The following is a description of a gene set: Mouse Gene Set: GOBP_SINGLE_STRAND_BREAK_REPAIR species: Mus musculus The repair of single strand breaks in DNA. Repair of such breaks is mediated by the same enzyme systems as are used in base excision repair., and this is the list of marker genes: Tdp1, Smc4 (NCBI Gene Id 97076), Aptx, Smc2 (NCBI Gene Id 67947), Ercc8, Aplf, Lig4, Trpc2, Sirt1, Ercc6, Tnp1, Parp1, Neil3, Xrcc1, Stk19